Given this list of marker genes NRAS, ERBB4, EREG, KRAS, HRAS, GRB2, HBEGF (NCBI Gene Id 1839), SHC1, NRG3, BTC, NRG1, NRG2, SOS1, NRG4, here is a description of the gene set: species: Homo sapiens Human Gene Set: REACTOME_SHC1_EVENTS_IN_ERBB4_SIGNALING SHC1 events in ERBB4 signaling